Given this list of marker genes CDKN2C, SMO, PTCH2, CCM2, COQ6, LZTR1, PTCH1, KRIT1, GNAS, NRAS, WRN, CREBBP, SEC23B (SEC23 homolog B, COPII coat complex component), MBD4, SMARCE1, LMNA, NTHL1, NF2, CHEK2, EIF3F, PDGFB, AKT1, ARMC5, PIK3CA, CDKN2B, SUFU, SDHD, SDHC, TERT, PTEN, MEN1, CDKN1B, BAP1, SMARCB1, CDKN1A, PDCD10, SDHB, KLLN, KDM1A, MN1, TRAF7, USF3, NF1, EP300, here is a description of the gene set: Meningioma studied in species Homo sapiens Human Gene Set: HP_MENINGIOMA The presence of a meningioma, i.e., a benign tumor originating from the dura mater or arachnoid mater.